Given this list of marker genes NUP50, NUP88, H4C16, NUP155, CBX2, H4C15, HDAC2, CBX4, SUMO2, SCMH1, H4C12, H4C11, NUP107, H4C14, BMI1, H4C13, HDAC4, SATB1, SEC13, H4C2 (H4 clustered histone 2), NUP42, PIAS2, PIAS1, NUP160, H4C4, NUP210, NUP37, NUP205, CHD3, NUP58, UBE2I, NUP43, PHC1, H4C1, CBX5, PCGF2, NUP93, NUP85, SEH1L, H4C6, NDC1, CBX8, SUMO1, POM121, RNF2, SUZ12, NUP35, NUP153, NUP98, H4C3, ZBED1, NUP62, NUP188, HDAC1, H4C8, RANBP2, SATB2, SUMO3, NUP54, H4C9, PHC3, L3MBTL2, NUP214, POM121C, NUP133, RAE1, AAAS, H4C5, PHC2, TPR, RING1, here is a description of the gene set: SUMOylation of chromatin organization proteins species: Homo sapiens Human Gene Set: REACTOME_SUMOYLATION_OF_CHROMATIN_ORGANIZATION_PROTEINS